The following is a description of a gene set: Human Gene Set: GOBP_CELLULAR_RESPONSE_TO_INCREASED_OXYGEN_LEVELS species: Homo sapiens Any process that results in a change in state or activity of a cell (in terms of movement, secretion, enzyme production, gene expression, etc.) as a result of a stimulus reflecting an increase in the level of oxygen., and this is the list of marker genes: CCDC115, ATP6V0D1, LCN2, ATP6V1A (NCBI Gene Id 523), FAS, NOX1, FOXO1, TMEM199, ATG7, ATP6V1G1, ATP6AP1, CAV1, ATP6V0A2